Given this list of marker genes SLC7A6, USP12, TSLP, GNG12, CHTF8, PAG1, LINC02953, GABBR2, SEMA4F, B3GNT3, SLC25A42, GAREM1, AOC3, CD44, NMT1 (NCBI Gene Id 4836), RBMXL3 (NCBI Gene Id 139804), RSF1, ST3GAL3, AMMECR1L (NCBI Gene Id 83607), ZNF93, UBE2J1, here is a description of the gene set: Genes predicted to be targets of miRBase v22 microRNA hsa-miR-6724-5p in miRDB v6.0 with MirTarget v4 prediction scores > 80 (high confidence targets). studied in species Homo sapiens Human Gene Set: MIR6724_5P from publication Chen Y, Wang X (PMID 31504780)